Given this list of marker genes Stat5b, Grb2, Il2rb, Il2rg, Il15, Shc1, Sos2, Jak3, Stat5a, here is a description of the gene set: Reactome Pathway: Interleukin-15 signaling part of: Interleukin-2 family signaling This event has been computationally inferred from an event that has been demonstrated in another species.<p>The inference is based on the homology mapping from PANTHER. Briefly, reactions for which all involved PhysicalEntities (in input, output and catalyst) have a mapped orthologue/paralogue (for complexes at least 75% of components must have a mapping) are inferred to the other species. electronically inferred by orthology from the curated human pathway species: Mus musculus